Given this list of marker genes XRN2, GPATCH3, HS1BP3, ACVR1, ATG4D, FPR2, CEBPZ, COL6A3, GPR68, ZCCHC4, DIRAS2, FGFR3, TMEM161A, CCNL1, NFIL3, PDCD6, DCTN3, EFCC1 (EF-hand and coiled-coil domain containing 1), TFAP4, ZNF638, GJA1, LEPROTL1, STAT3, SLC22A3, REPIN1, ZMYM6, ZNF566, PTGS2, DCX, TLN1, CCAR2, MAP1S, SELE, FAR2, BTN2A1, CCDC102A, CHD9, MBD5, FLJ13224 (NCBI Gene Id 79857), NHSL3, ANKRD13A, SELPLG (selectin P ligand), GPSM3, FAM220A, MTMR12, PTPRT, DHRS12, UNC79, MRPL27, MRPL18, TESPA1, ACTR6, MED12L, PDCD5, GRAPL-AS1, RERE, P4HTM, NECAP2, CELF2, GEMIN7, SLC26A8, HNRNPH3, LMTK3, CXCL8, OSBPL9, IGKC, ALG6, SLMAP, KAT2B, INO80B, LAIR1, ZNF202, CENPK, CSF1, MRPL47, POU6F2, S100A5, PYGB, ASXL2, TRIM7, GLT8D1, SMG7, DDX17, SPAG9 (sperm associated antigen 9), PLEKHG1, CELP, CDH5, RABGAP1, PLGLB2, SYCP2, DCLK1, GALNT3, FAM3B, CCBE1, NRL, PKIA, BARD1, NANS, SLC25A27, ACKR1, SLC11A2, POGLUT2, BCL2L13, SCD, PORCN, PTX3, CTSZ, QKI, HOXD13, BEGAIN, TP53, NGF, TRMT6, SURF6, ZBTB5, PNPLA2, ISCU, SLC19A1, CAPRIN1, EDN1, SARAF, TRIM14, PRDM1, PDE4D, MYEF2, TRABD, MYH1, MICB, PYCR3, PLEKHF2, TTF2, FABP2, FGD6, ACSBG1 (NCBI Gene Id 23205), CHST1, GOLGA4, TIMP4, PCDHB7, RNF220, LYL1, RNF103, WRNIP1, GSTZ1, YWHAB, MED25, TSC22D3, BAIAP3, CIP2A, MCTS1, CDK16, UBE2J1, SLC9A6, CYP2C9, ZKSCAN7, EPS15L1, NME1, SOX6, NEIL1, HIVEP2, SUGP2, NUP54, SOX21, MED14, CLEC2B, BEND5, RHPN1, RALGPS2, RFC2, KLHL36 (kelch like family member 36), RBM7, CD1D, PGLYRP2, WDR25, LMO7, PDCD2L, DIO3, FNBP4, INIP, PLIN1, LILRA4, RALB, DCANP1, CCDC134, AGAP2, PRDM8, CCDC81, CCNH (cyclin H), DDX60, TMEM121B, MICALL1, CYP1A1, CSGALNACT2, PCSK5, MAP6D1, REV3L, EGFR, HOXC4, NUP58, LY86, TDP1 (tyrosyl-DNA phosphodiesterase 1), TMEM97, MCMBP, OR7E12P, ILRUN, TBC1D9, SPMAP2, BCR, BASP1, CEP162, SIAH1, MMP7, TMLHE, CDH22, SNX5, RNASEL, SH3BP2, METTL22, GJC2, PARS2, TUBA4A, SP140L, HSD17B12, DES, MYL12A, PCGF1, MST1R, ABL2, LINC00160, GGA2, KLHL4, WDR46 (WD repeat domain 46), MOCOS, LDAH (lipid droplet associated hydrolase), BPIFA1, SLC43A1, GPR137B, CDH4, PIF1, PHF3, TMEM144, ERLIN2, NDRG2, IMMT, ITGB5, WNT2, PNMA8A (PNMA family member 8A), CORIN, FURIN, BCL2L14, HYAL2, PPP1R14D, PAPOLA, ENC1, GSTM4, SV2B, QSOX1, CYP2B7P, PTPRZ1, EEF1D, KRT19, C17orf75, KATNIP, UFL1, BPTF, SMAD3, DZIP3, OR2A1, RXRA, SFT2D3, BFSP2-AS1, TMF1, CPNE1, SSBP4, CLCF1 (NCBI Gene Id 23529), MXRA8, LRP3 (NCBI Gene Id 4037), TIMELESS, SENP1, TBC1D8B, DPYD, XPO4, BRAP, CD8A, MAGED4B, NEPRO (nucleolus and neural progenitor protein), EARS2, CAND1, CMTM6, TMED3, TMEM120A, GLB1L, NPY1R, VEGFC, MAGEL2, FOS, ZNF143, STAMBPL1, ESPN, ZFP41, CHD1, HNRNPU, IL18R1, RARG, BAG3, SF3A1, ZMAT4, LRRC4C, IL1RL1, CST1, OXGR1, EYA3, KDM4D, ATP8A2, LARP1, SLC5A4, EIF2B4, HMGN5, UGCG, KCNE4, KDM5B, FBXO11, CD9, C19orf73, MAPKBP1, TIMP2, CCDC90B, ELAC1, ELMO1, ART3, HNRNPDL, WDR19, ARHGAP15, RRAGD, ITK, SNTB2, PI4K2B, ZMYM5, ARID5A, PPP1CB, ADIPOR2, CYYR1, AMIGO1, UTP11, MED24, NACAD, TAL1, MRPL36, AMZ2, TRAF3, KLHL41, DEXI, SH2B3, DNAAF4, CCDC85C, GREB1, PITPNC1, RARB, ISYNA1, ZNF318, MTTP, PPP4R2, BHMT2, ORC3, ERVMER34-1, CHST9, ATG16L1 (autophagy related 16 like 1), TNFRSF13C (TNF receptor superfamily member 13C, NCBI Gene Id 115650), ZNF764, IL1R2 (interleukin 1 receptor type 2), EPCIP, CHAF1A, PHAX, ALDOA, LANCL2, PLAAT4, COCH, ARHGAP45, PCED1B, RPRM, NUTM2F, MMP14, TGFBR3, GATA3, IRF5, CD302, CUL9, TSLP, COQ8A, KIAA2013, PAWR, CCNG1, IFI27, FBXW4, CACNA2D3, MOB4, NOL7, SLC17A8, NCOA7, OBSCN, POLDIP3, ITGAM, CEP55, TOR4A, HACD1, NOP53, GSTM1, MORC3, HBE1, ZNF117, SLAMF7 (SLAM family member 7), CLUH, DHODH, COPE, ZNF264, UFSP2, TMEM248, GJA5, CDH13, MREG, LHPP, ELOB, ANKRD1, GEMIN4, SDC3, NELFB, KATNAL1, NR2E1, CD1A, CITED2, KLF13, SPNS1, ATG2A, OTOR, FMN1, PTPRF, TMEM62, VIT, FAF1, ABI3 (ABI family member 3), EPHA7, CDK11A, GCA, GABPB1-IT1, BSDC1, NMT1, HINT3, NSUN3, PPIL2, BRIP1, NXF1, NXPH4, MPRIP, ZGRF1 (zinc finger GRF-type containing 1), ATXN7, SCARA3, MAP4, ABCC1, CHL1, ZBTB7A, BMX, ATRN, TMEM250, CYP2A7, AASS, ENPP1, IPCEF1, AKAP8L, SAV1, DYNC2LI1, TNFSF4, ELOVL2, STRIP2, here is a description of the gene set: species: Homo sapiens Genes in the cancer module 37. Human Gene Set: MODULE_37